Given this list of marker genes Spry4, Fgr, Them4, Wwc1, Fermt1, Mtmr6, Myo6, Pip5k1a, Itga5, Sh3bgrl3 (NCBI Gene Id 73723), Trpv4, Pacsin2, Eps8l1, Eef1a1, Egfr, Fap, Mtss2, Cib1, Hip1r, Ptprz1, Psd4, Rigi, Aif1, Ptprj, Eps8l2, Myo1c, Sntg1, Epb41l5 (NCBI Gene Id 98492), Tiam1, Aif1l, Inpp5j, Mtmr9, Synj2, Diaph1, Tesc, Kcnn4, Arhgef2, Eps8l3, Fgd5, Abca7, Pla2g4f (phospholipase A2, group IVF), Tpm1, Akt2, Nme1, Tirap, Fgd2 (FYVE, RhoGEF and PH domain containing 2), Eps8, Psd, Itgav, Ezr, Kank1, Bmx, Apc, Arhgap45, Plcg1, Spata13, Dnm2, Rasgrp2, Map2, Sh2d3c, Arpc2, Inpp5k, Itgb3, Itgb1, Psd2, Cfl1, Twf1, Pacsin1, Plekha1, Lcp1, Cdc37, Spry2, Pip5k1c, Fam107a, Epha2, Ppp1r9b, Plcg2, Psd3, Macf1, Clasp2 (CLIP associating protein 2), Coro1c, Sh3yl1, Rac1, Jcad, Plekho1, Tln1, Adam17, Pde9a, Plek, Erbb2, C2cd5, Ksr1, Arf4, Appl2, Dlc1, Pak1, Pdxp, Src, Rhoa, Pdpn, Rps3, Cdkl5, here is a description of the gene set: The portion of the plasma membrane surrounding a ruffle. species: Mus musculus Mouse Gene Set: GOCC_RUFFLE_MEMBRANE